Given this list of marker genes GAB2, SNAP23, FCER1G, HAVCR1, RAC2, NECTIN2, NDRG1, LYN, SYK, ADORA2B, RASGRP1, NR4A3, VAMP7, PIK3CG, SCN11A, FCER1A, GRP, CHGA, VAMP3, IGHE, FES, STXBP2, CNR2, CD300A, FGR, PTGDR, RHOH, SPHK2, VAMP2, FER, PLA2G3, S100A12, CD84, PIK3CD, IL13, SNX4, KIT, GPR15LG, VAMP8, FERRY3, GATA2, ADGRE2, ENPP3, LAT, S100A13, CRLF2, PTPRE (NCBI Gene Id 5791), PDPK1, LGALS9, FCGR2B, RAB44, UNC13D (unc-13 homolog D), MILR1, CPLX2, CLNK, PLSCR1, RABGEF1, TSLP, PTPN6, IL4R, GATA1, CBL, LAT2, BTK, MRGPRX2, SLC18A2, STXBP1, LCP2 (lymphocyte cytosolic protein 2), IL13RA2, PTGDS, CD226, SNX6, FOXF1, CD300LF, here is a description of the gene set: The change in morphology and behavior of a mast cell resulting from exposure to a cytokine, chemokine, soluble factor, or to (at least in mammals) an antigen which the mast cell has specifically bound via IgE bound to Fc-epsilonRI receptors. species: Homo sapiens Human Gene Set: GOBP_MAST_CELL_ACTIVATION